The following is a description of a gene set: The portion of the plasma membrane surrounding a lamellipodium. Human Gene Set: GOCC_LAMELLIPODIUM_MEMBRANE studied in species Homo sapiens, and this is the list of marker genes: PLEK2, VASP, SLC39A6, ITGB3, PLXND1, FERMT2, KCNA2, ANTXR1, PDXP, CSPG4, CFL1, SYNE2, DPP4, CD44, APC2, PIEZO1, DOCK8 (dedicator of cytokinesis 8), EPHA2, FAP, ITGAV, NCKAP1, PDPN